The following is a description of a gene set: The chemical reactions and pathways involving a hydrocarbon, a compound consisting of carbon and hydrogen only. Human Gene Set: GOBP_HYDROCARBON_METABOLIC_PROCESS species: Homo sapiens, and this is the list of marker genes: BCO1, EPHX1, CYP2F1, CYP1A1, BCO2, CYP2E1, GRIN1